The following is a description of a gene set: Abnormal circulating monocarboxylic acid concentration Human Gene Set: HP_ABNORMAL_CIRCULATING_MONOCARBOXYLIC_ACID_CONCENTRATION Any deviation from the normal concentration of a monocarboxylic acid in the blood circulation. species: Homo sapiens, and this is the list of marker genes: SCO2, SLC25A26, IVD, NDUFS6, SLC22A5, ATP8B1, COX10, LIPT2, UPB1, SLC2A2, KARS1 (lysyl-tRNA synthetase 1), NDUFAF3, FOXRED1, PKHD1 (NCBI Gene Id 5314), PGM2L1, ALDH5A1, ACAD8, MMAB, NDUFS2, AMACR, VPS50, ALDH4A1, NDUFAF2, NFU1, MCCC2, VPS33B, NDUFA11, NDUFB9, TRMU, LDHA, ATAD1, TANGO2, NDUFS3, MPV17, MT-TL1, TIMMDC1, TALDO1, COL7A1, MT-ND2, MMP1, GCDH, ACAT2, LONP1, KIF12, NDUFV2, EHHADH, TMEM126B, MT-TE, ALDH7A1 (NCBI Gene Id 64414), NDUFA6, BCS1L, ABCB11, COX6A2, GATM, LYRM7, NDUFV1, SLC10A1, NUBPL, SLC52A1, MT-TF, PITRM1, CTNS, NDUFAF5, CCDC47, NDUFAF4, MT-ND3, NDUFB10, NDUFA2, UNC45A, ABCB4, DNAJC21, HMGCL, LMBRD1, NDUFB11, PNPLA8, MCEE, SLC25A20, SEMA7A, MT-TP, SBDS, DLD, POLG, PEX26, SCO1, ACADS (NCBI Gene Id 35), EFL1, MT-ND1, HADH, NDUFB3, ABCD4, NDUFAF6, MYO5B, NDUFS8, ACAD9, AP1B1, NR1H4, TJP2, ABCD3, ETHE1, NADK2, NDUFA1, CPT2, AIFM1, ACADVL, OBSCN, PDHX, MECP2, DZIP1L, MPC1, SLC34A1, UQCRC2, NDUFS1, DNM1L, NDUFAF1, SLC51B, AKR1D1 (NCBI Gene Id 6718), NDUFS7, MT-TK, PDHA1, NDUFS4 (NADH:ubiquinone oxidoreductase subunit S4), HADHA, MMACHC, NDUFAF8 (NCBI Gene Id 284184), ACADM, SDHB, TWNK, MT-TI, COX16, SLC25A13, PC